Given this list of marker genes Bckdk, Rtkn2, Cpt1a, Capn12, Cnot7, Phf21b, Noc3l, Igdcc4, Afg2a, Rprm, Ppp1r18, Nyap2, Znrf3, Chrna1, Tlnrd1, Dlg4, Samd4, Asah2, Map1b, Fgfr1op2 (NCBI Gene Id 67529), Bdh2, Dcun1d1, Gkn1, Tspan5, Lman2l, Lrp12, Ganc (glucosidase, alpha; neutral C), 4933405O20Rik, Arhgap12, Ccn2, Bhlhe22 (NCBI Gene Id 59058), here is a description of the gene set: from publication Chen Y, Wang X (PMID 31504780) Mouse Gene Set: MIR_6908_3P Genes predicted to be targets of miRBase v22 microRNA mmu_miR_6908_3p in miRDB v6.0 with MirTarget v4 prediction scores > 80 (high confidence targets). species: Mus musculus